Given this list of marker genes KIF1C, TUBA3C, KLC2, TUBA3E, KIF4A, KIF5B, TUBB1, KIFC1, RACGAP1, KIF21A, TUBAL3, KIF3B, KIF1B, KIF26A, TUBA3D, KLC3, KIF13B, TUBA4B, KIF11 (kinesin family member 11, NCBI Gene Id 3832), TUBB6, TUBA1B, KIF6, TUBB8, TUBB3, KIF3A, TUBA8, TUBB8B, KIF27, TUBA1C, TUBB2A, KIF20A, KIF5C, KIFAP3, CENPE, KLC1, KIF18B, TUBA1A, KIF1A, KIF28P, KIF4B, KIF21B, TUBA4A, KIF2B, KIF2C, KIF2A, KIF15, KIF26B, KIF20B, TUBB2B, KIF3C, KIF19, KIF12, KIFC2, KIF5A, TUBB4B, KLC4, KIF25, TUBB4A, KIF23, KIF16B, KIF18A, KIF9, KIF22, here is a description of the gene set: Reactome Pathway: Kinesins species: Homo sapiens Kinesins are a superfamily of microtubule-based motor proteins that have diverse functions in transport of vesicles, organelles and chromosomes, and regulate microtubule dynamics. There are 14 families of kinesins, all reprsented in humans. A standardized nomenclature was published in 2004 (Lawrence et al.). part of: Factors involved in megakaryocyte development and platelet production